Given this list of marker genes ZNF839, NCOA7, RNU6ATAC, WBP4, KLF2, HSPA6, PLXDC1 (plexin domain containing 1), NDUFS7 (NCBI Gene Id 4727), H3C9P, WASF4P, FMC1, ALOXE3, PSMB3, B4GAT1-DT, HJV, RNY1 (NCBI Gene Id 6084), C2orf42, MAP1LC3B, LINC02453, CCDC107, RAD51AP1, MIR4521, TAGLN2, CGB1, RFX3-DT, VTRNA1-3, PRMT5, ECT2, MYNN, COX8CP1, B4GAT1, LINC02136, PGK1, RFX1, ENSG00000228151, BCYRN1, RNY3, ANG, TIA1, FBXO31, RN7SL2, BCAR3, LINC01623, H4C8, ENSG00000238142, LINC00240, POLR3E, DPP9, RAB11A, CFAP418, GHET1, PPEF1, MIR7-3, VTRNA1-1, RNU6-8, BRPF1, HMGN4, MUS81, ILF2, LASP1, GARS1-DT, LTA4H, FMC1-LUC7L2, METTL26, RNASE4, RN7SL1, CGB2, RNU1-5P, RFX3, LINC03126, HARBI1, MED16, PRMT5-DT, SMARCC2, HCG14, LIMD1-AS1, MYADM, SFSWAP, SACM1L, CFL1, RNASE11, CDKL4, VTRNA2-1 (vault RNA 2-1), KLF2-DT, LINC01556, ARL1, MIR7-3HG, FERRY3, SETD1A, AGBL5-AS1, VTRNA1-2, PPP6R3, JUND (JunD proto-oncogene, AP-1 transcription factor subunit), ZNF131, KNL1, ACTB, RPS29, PLEKHG2, RNU6-9 (RNA, U6 small nuclear 9), CIITA, SHF, SLC27A4, MCRIP2, PAMR1, TIMM22, RNU6-2, ATG13, POLG, LINC02739, LRP3, ZSCAN18, RNU1-6P, GARS1, CD83P1, GSTA4, TMEM259, AGBL5 (NCBI Gene Id 60509), TRIM41, POLG-DT, MIR3188, BTBD19, DYNLT4, TRIM7-AS2, RNY4, RNU6-1 (RNA, U6 small nuclear 1), KRT8, RNA5SP304, PARP2, RELB, here is a description of the gene set: species: Homo sapiens Human Gene Set: TERT_TARGET_GENES from publication Yevshin I, Sharipov R, Kolmykov S, Kondrakhin Y, Kolpakov F (PMID 30445619) Genes containing one or more binding sites for (TERT) in their promoter regions (TSS -1000,+100 bp) as identified by GTRD version 20.06 ChIP-seq harmonization.